Given this list of marker genes Pdgfb, Esr1, Cdc6, Prkdc, Myb, Tgfb1, Cd248, Pdgfd, Ctc1, Cd74, Rnaseh2b, Dhx9, Wnt5a, Zmiz1, Mif, Fbln1, Cdkn1a (NCBI Gene Id 12575), Bmi1, Icmt, Hras, Fosl2, Ccnb1, Sphk1, Phip, Cdk4, Pla2g1b (NCBI Gene Id 18778), Ccna2, Tgif1, Fndc3b, Kmt2c, Grk2, E2f1, Lig4, Egf, Rasa1, Agt, Ngfr, Cdk6, Nras, Dicer1, Fn1, Fbrs, Serpine1, Itgb3, Hmga2, Wnt2, Lif, Uts2r, Cripto, Aqp1, Ager, Gas6, Pdgfra, Mir744, Rasgrf1, Abl1, Uts2, Myc, Pdgfa, Pml, Ndufs4, Ddr2, Sirt6, Fntb, Wnt1, Pdgfrb, Jun, Pdgfc, Ereg, Anxa2 (annexin A2), Xrcc4, Il13, Btc, Fgf10, Ptprz1, Brk1, Bmyc, Igf1, Egfr, here is a description of the gene set: studied in species Mus musculus Any process that activates or increases the frequency, rate or extent of multiplication or reproduction of fibroblast cells. Mouse Gene Set: GOBP_POSITIVE_REGULATION_OF_FIBROBLAST_PROLIFERATION